Given this list of marker genes Runx2, Tcf15, Ggt1, Acvr1, Pitx2, Wnt10a, Ptprc, Hhex, Edn3, Nr6a1, Yap1, Sp7, Mir452, Mir154, Dnmt3l, Ell3, Mbd3, Ext1, Sfrp1, Smad5, Mtf2, Hdac2, Rps7, Esr1, Sox5, Rbbp4, Nfe2l2, Cyp26a1, Tead2, Slc4a11, Slc9a1, Mapk3, Kdm3a, Alx1, Ccnk, Foxc2, Gatad2b, Gatad2a, Lmbr1l, Ltbp3, Ufl1, Ankrd11 (ankyrin repeat domain 11), Cdc42, Phf5a, Osr1, Crxos, Batf, Mir155, Tbx18, Nrp1, Ociad1 (NCBI Gene Id 68095), Tbx5, Smad4, Lif, Cdk13, Cdk12, Smyd5 (NCBI Gene Id 232187), Prkdc, Pdgfra, Trp53, Kbtbd8, Mir125a, Tmsb4x, Klhl12, Ptn, Mir130a, Gsk3b, A2m, Snai2, Mir203, Dhx36, Sema3e, Pax6, Msx2, Kdm4c, Fgfr2, Sema3d, Mirlet7e (microRNA let7e), Mllt3, Mir125b-1, Ncoa3, Sema6b, Myocd, Tal1, Mir542, Sox21, Zic3, Tbx1, L3mbtl2, Sema5b, Pef1, Kitl (kit ligand), Mta1, Phox2b, Sema4a (NCBI Gene Id 99554), Eif2ak2, Bmp4, Sox18, Bcl2, Fgf15, Mir100, Otud5, Htr2b, Wnt7b, Nanog, Pdx1, Radil, Sh2b3, Fbxl17, Jarid2, E230001N04Rik, Phactr4, Ednra, Nrg1, Hoxd4, Sema6a, Ccdc88c, Mta2, Itgb1, Prkca, Phf19, Pus7, Sema4c, Eng, Tcf7l1, Nolc1, Sox17, Hesx1, Zscan10, Msx1, Sema3g, Mir7-1, Esrrb, Sema7a (NCBI Gene Id 78407), Etv4, Foxa1, Zic5 (zinc finger protein of the cerebellum 5), Sema5a, Nr5a2, Prickle1, Tgfb2, Cdh2, Rbm24, Fzd1 (frizzled class receptor 1), Pdcd6, Bmp7, Mir137, Sox9, Ret, Bbs12, Sox8, Tacstd2, Frzb, Cyp26c1, Dmrta2, Gsc, Mir193b, Isl1, Foxo4, Sox2, Twist1, Rest, Krt10, Lbh, Ctnnb1, Setd6, Sema4d, Six1, Sema6d, Ovol2 (NCBI Gene Id 69059), Cited2, Lin28a, Sema3c, Zeb2, Tcof1, Ercc2, Xrcc5, Gak, N4bp2l2, Gbx2, Fn1, Tapt1, Msi2, Fbxo21, Fgfr1, Notch1, Bmpr1a, Mir126a, Epop, Hoxa7, Nrtn, Hnf1b, Tbx3, Mettl5, Aldh1a2, Sema4b, Pax2, Folr1, Mta3, Hand2, Sox6, Smad9, Eomes, Chd2, Wnt7a, Mapk14, Gdnf (NCBI Gene Id 14573), Sema3b, Ttyh1, Rbpj, Eef1ece2 (NCBI Gene Id 110599584), Jag1, Zscan4c, Sirt6, Tgfbr2, Gpm6a, Ezh2, Trp63, Mettl3, Sema4f, Rdh10, Cfl1, Mapk1, Pwp1, Smo, Nsun2, Mir181c, Hif1a, Pax3, Ednrb, Tbx2, Mir34a, Zfp36, Chd4, Wnt3, Psmd11, Nelfb, Vsir, Fgf2 (NCBI Gene Id 14173), Pum1, Bmpr2, Ythdf2, Nog, Ift80, Smad1, Nkx2-5 (NCBI Gene Id 18091), Sox10, Lama5, Zfp36l2, Lrp6 (NCBI Gene Id 77387), Tfap2c, Bvht, Pou5f1, Sema3f, Grem1, Trim6 (NCBI Gene Id 94088), Shh, Rbbp7, Hoxb4, Zic2, Setd1a, Ap2a2, Kit, Kat5, Nudt21, Mir7-2, Epcam, Meox1, Ndufs6, Mir99a, Mtch2, Cdx2, Hdac1, Coro1c, Foxc1, Terc, Sema6c, Hes1, Hes5, Mef2c, Krt14, Hspa9, Sema3a, Stat3, Erbb4, Sema4g, Prdm4, Arb2a, Gata6, Med1, Cdk6, Shc4, Nrp2, Zfp281, Srf, Men1, Fancb, Setd2, Dicer1, Mir125b-2, Sfrp2, Efnb1, Hnrnpu, T, Edn1, Tfap2a, here is a description of the gene set: The process in which a relatively unspecialized cell acquires specialized features of a stem cell. A stem cell is a cell that retains the ability to divide and proliferate throughout life to provide progenitor cells that can differentiate into specialized cells. Mouse Gene Set: GOBP_STEM_CELL_DIFFERENTIATION species: Mus musculus